Given this list of marker genes Gas2l2, Ccdc40, Cyb5d1, Dnah11, Bbs2, Spag6l, Dnaaf1, Ttll6, Cfap43, Bbs4, Catsper1, Ccdc39, Odad2, Bbs1, Mkks, Cfap45, Cfap20, Cfap206, here is a description of the gene set: Mouse Gene Set: GOBP_REGULATION_OF_CILIUM_BEAT_FREQUENCY Any process that modulates the frequency of cilium movement, the directed, self-propelled movement of a cilium. studied in species Mus musculus